Given this list of marker genes Tmed10, Ctsc, Cnih1, Sec24d, Gria1, Mcfd2, Serpina1c, Sec22b (NCBI Gene Id 99656), Preb, Mia2, Lman1, Sar1b, Mia3, Cnih2, Tmed2, F8, Gosr2, Sec24a, Lman2, Sec23a, Cnih3, Ctsz, Folr1, F5, Sec24c, Lman1l, Tgfa, Serpina1b, Lman2l, Stx5a, Cd59b, Sec24b, Areg, Col7a1, here is a description of the gene set: Mouse Gene Set: REACTOME_CARGO_CONCENTRATION_IN_THE_ER Cargo concentration in the ER studied in species Mus musculus